The following is a description of a gene set: Genes having at least one occurence of the motif TTTGTAG in their 3' untranslated region. The motif represents putative target (that is, seed match) of human mature miRNA hsa-miR-520d* (v7.1 miRBase). studied in species Homo sapiens Human Gene Set: TTTGTAG_MIR520D, and this is the list of marker genes: SOX1, H3-5, ATP2B1, TAFA5, SLC35F1, PRPF39, RAI14 (NCBI Gene Id 79367), DIRAS2, TCTN2, CEP350, TPST1, AFF4, HNRNPA0, UBE2E3, NAV3, PCGF3, ELAVL1 (NCBI Gene Id 1994), RSBN1, HOXA7, PHF6, DDIT4L, PURA, BOLA2, DAPK1, DCP2, PRDM2, NAT8L, TMEM200A, SCN3A, UBE3C, NEUROG2, CDIP1, NIPBL (NCBI Gene Id 25836), C4orf17, HNRNPM, PPP2CA (NCBI Gene Id 5515), MEX3B, CSTF3, ATXN2 (ataxin 2), CAND1, TUSC2, METTL9, TXN2, RDX, ZFX, LRRC8D (NCBI Gene Id 55144), CUX1, SON, SLITRK2, KCNK1, SCD (stearoyl-CoA desaturase), PIWIL4, NR5A2, ENAH, GPM6B, IL20RA, IL1RAPL1, SYNPR, SYT1, TRPC4, HTR7, CBX3, BSDC1, FBN2, TEAD1, MBNL2, MDM1, PLEKHH3, DACH1, NBEA, DKK2, VAMP2, ARRDC1, DDX17, BMI1, BRINP3, CDC42BPB, HNRNPDL (NCBI Gene Id 9987), PPM1D, CLNS1A, PIP4P2, EIF3A, STXBP5, IGF2BP3, TSHZ1, SERTAD2, ELF1, MORC3, FBXO22, XPO5, SP4, BZW1, PCDH19, PDCL, GPATCH8, LUC7L, ETV5, UBQLN2, EIF4G2, ZBTB6, POU4F2, RAP2A, PUM1, OSBPL10, SORCS1, STK17B (NCBI Gene Id 9262), COCH, ADIPOR1, LRRC59, RFX3, UBR7, IER5, NHLH2, VMAC, SBF2, USP33, RNF44, CUEDC1, ARL8B, RFX1, ZZZ3, PIKFYVE, ATXN1, SP3, NDFIP1, KDELR1, FMN2, NFYB, EDEM3, ERLIN2, SETD1A, TMPO, LRRN1, FOSL1, AMMECR1L, RFX4, ANGPTL5, ZNF22, SDC2, ZKSCAN5, ATP2A2, KLF11, RPS6KB1, PTPN2, HES5, SESTD1, SLAIN1, RLIM, MTSS1, SKIC8, PPARGC1A, CASP8AP2, TMEM47, ADD1, NRXN3, CPEB2, SMOC1, MEF2C, SCN5A, HES1, DNAJC6, KMT5A, UBR5, BHLHE41, PHLPP1, PRPF38B, TRAM1, TOX, PHF2, NPAS4, MTA1, SPIN1, HFM1, PTPRZ1, MAP3K2, FAM53B, PPP1R26, SRSF6, USP47, GNL1, CDH2, MLLT10, HOXB6 (homeobox B6), CCND1, TAB3, SULF2, CPEB4, TBC1D15, CTCF, GPM6A, UBE2L3, ZNF385B, TIPARP, GNAO1, WASF2, NEXMIF, SEC62, MAPKAP1, GABRA1, PCNP, H3-3B, DCLK1, ABCA1, SRSF1, PRP4K, GADD45A, CNTNAP2, BAZ2B, ARL4A, TMEM165, PDE4D, PDZRN3, STX12, ANKRD10, DHX32, SEMA4G, MIER1, ABHD3 (NCBI Gene Id 90492), LPP, GRM3, ACACA, VCPIP1 (NCBI Gene Id 80124), PRDM1, ZFHX4, VGLL4, PURB, H3-3A, CELF2, ATF4, GOLT1B, TCF7L2, PTN, MAFF, LRCH4, PFN2, MTF2, CCT8, AGO1, TRPS1, SLC35F5, CNOT1, SLC1A3, KIF11 (NCBI Gene Id 3832), SPATS2L, PPP3CA, TBL1XR1, BRWD1, EGR3, EGFLAM, KLF12, NXF1, ABCC12, TAL1, KCNMA1, RANBP2, PDCD4, UBE3A, SIK1, GIPC2, HDAC4, SRC, STON1, SEH1L, CBX4, CNEP1R1, CITED2, NDEL1, LYSMD2, COL24A1, SLITRK3, STK4, ACTL6A (actin like 6A), MSL2, FNTA, NEDD9, FOXN3, RICTOR, SMOC2, IGDCC4, CRHBP, NPTX1, CTDSPL2, CNTLN, NEBL, GTPBP1, SOCS5, NCAM1, LRBA, POLR2B, UNC79, ADCYAP1, BTBD3, MECP2, CMTM4, SERPINF2, ETS1, PCMTD1, JADE2, PPM1E, SALL3, ODC1, PTP4A1, NCBP3, FKBP1A, HOXB5, MOCS2, GAD1, U2AF1, NEUROG1, ELOF1, ZMYM2, ARGLU1 (arginine and glutamate rich 1), RCE1, SETD7, SNAP25, PPP1CB, SIRT1 (NCBI Gene Id 23411), SRSF5, JAZF1, LIN28A, QKI, FNBP1L (formin binding protein 1 like), LUC7L3 (NCBI Gene Id 51747), HOXD3, RBM47, LLGL2, BIVM, LRP11 (LDL receptor related protein 11), UHRF1, JMJD1C, IGF1, TAB2, LRATD2, SOX11, UBE2W